The following is a description of a gene set: species: Homo sapiens Increase in size of one or more joints. Enlarged joints Human Gene Set: HP_ENLARGED_JOINTS, and this is the list of marker genes: LIFR, SRCAP, RAB33B (RAB33B, member RAS oncogene family), HOXD13, TRPV4, COL11A2, MATN3, SMARCA2, KAT6A, CCN6, CHST3, KIF7, GNPNAT1, COL2A1